Given this list of marker genes CD4, RAG2, CD5, RAG1, BCL2L1, RORC, PTCRA, BCL2, CD6, ID2, here is a description of the gene set: Analysis of the INK4A/ARF locus in human T-ALL patients revealed frequent deletions in exon 2, the exon common to both p16(INK4A) and p14(ARF). Other studies have described selective deletion of exon 1beta of p14(ARF) or methylation of the p16(INK4A) promoter. Therefore, it is unclear from these studies whether loss of p16(INK4A) and/or p14(ARF) contributes to the development of T-ALL. To elucidate the relative contribution of the ink4a/arf locus to T-cell leukemogenesis, we mated our tal1 transgenic mice to ink4a/arf-/-, p16(ink4a)-/-, and p19(arf)-/- mice and generated tal1/ink4a/arf+/-, tal1/p16(ink4a)+/-, and tal1/p19(arf)+/- mice. Each of these mice developed T-cell leukemia rapidly, indicating that loss of either p16(ink4a) or p19(arf) cooperates with Tal1 to induce leukemia in mice. Preleukemic studies reveal that Tal1 expression stimulates entry into the cell cycle and thymocyte apoptosis in vivo. Interestingly, mice expressing a DNA-binding mutant of Tal1 do not exhibit increases in S phase cells. The S phase induction is accompanied by an increase in thymocyte apoptosis in tal1 transgenic mice. Whereas apoptosis is reduced to wild-type levels in tal1/ink4a/arf-/- mice, S phase induction remains unaffected. Thus, Tal1 stimulates cell cycle entry independent of the ink4a/arf locus, but its ability to induce apoptosis is Ink4a/Arf-dependent. Human Gene Set: SHANK_TAL1_TARGETS_DN from publication Shank-Calvo JA, Draheim K, Bhasin M, Kelliher MA (PMID 16407836) studied in species Mus musculus Genes down-regulated in preleukemic thymocytes from transgenic mice which overexpress TAL1 in thymus.